The following is a description of a gene set: Mouse Gene Set: CUI_B_CELL_IL17B_RESPONSE_UP from publication Cui A, Huang T, Li S, Ma A, Pérez JL, Sander C, Keskin DB, Wu CJ, Fraenkel E, Hacohen N (PMID 38057668) studied in species Mus musculus Cytokines mediate cell-cell communication in the immune system and represent important therapeutic targets. A myriad of studies have highlighted their central role in immune function, yet we lack a global view of the cellular responses of each immune cell type to each cytokine. To address this gap, the authors created the Immune Dictionary, a compendium of single-cell transcriptomic profiles of more than 17 immune cell types in response to each of 86 cytokines (>1,400 cytokine-cell type combinations) in mouse lymph nodes in vivo. A cytokine-centric view of the dictionary revealed that most cytokines induce highly cell-type-specific responses. For example, the inflammatory cytokine interleukin-1β induces distinct gene programmes in almost every cell type. A cell-type-centric view of the dictionary identified more than 66 cytokine-driven cellular polarization states across immune cell types, including previously uncharacterized states such as an interleukin-18-induced polyfunctional natural killer cell state. Genes positively differentially expressed in cell type: B cell upon treatment with cytokine: IL-17B in mouse lymph nodes in vivo., and this is the list of marker genes: Tmsb10, Glmp, Pfn1, Manf, Pdia3